Given this list of marker genes CEACAM18, TRIM15, NLRP6, SLC34A3, LINC01594, ACSL5, XDH, LINC00955, RNU6-36P, RPL13AP8, BTNL8, TMEM207, LCT (lactase), CEACAM19, PRKG2, TMIGD1, STRC, LINC01123, LHPP, ENPP7, PGPEP1, FGF23, ANXA13, GBA3, IGSF23, AGMAT, REEP6, TINAG (NCBI Gene Id 27283), NHERF4, TM6SF2 (transmembrane 6 superfamily member 2), MELTF, DEFA5, PDZD7, XPNPEP2, CLCA1, ERICH4, MUC12, WHAMM, C1QTNF12, DGAT1, CDX2, CUBN, CBLC, POFUT1, RNU6-439P, SLC26A3, SLC17A4, CA7, MALRD1, LBX2, ZBTB38, LPGAT1, KHK, PANCR, TPSG1, ACY3, FADS6 (NCBI Gene Id 283985), MYO1A, URAD, VIL1, SI, SPACA3, DNAJB7, BTNL3, GUCA2A, PVALEF, APOA4, SLC28A1, R3HDML, MIR4307HG, APRG1, FAM157A, RBBP8NL, CLCN1, RBP2, ENTPD7, PRSS48, CYP2W1, LCN15, MOGAT3, RPLP0P2, SLC13A2, MUC2, C3orf85, GPR35, MTTP, ANKRD40CL, SLC5A12, LINC02323, DEFA6, here is a description of the gene set: The gene expression program underlying the specification of human cell types is of fundamental interest. The study authors generated human cell atlases of gene expression and chromatin accessibility in fetal tissues. For gene expression, the study authors applied three-level combinatorial indexing to >110 samples representing 15 organs, ultimately profiling ~4 million single cells. The study authors leveraged the literature and other atlases to identify and annotate hundreds of cell types and subtypes, both within and across tissues. Our analyses focused on organ-specific specializations of broadly distributed cell types (such as blood, endothelial, and epithelial), sites of fetal erythropoiesis (which notably included the adrenal gland), and integration with mouse developmental atlases (such as conserved specification of blood cells). These data represent a rich resource for the exploration of in vivo human gene expression in diverse tissues and cell types. Human Gene Set: DESCARTES_MAIN_FETAL_INTESTINAL_EPITHELIAL_CELLS studied in species Homo sapiens from publication Cao J, O'Day DR, Pliner HA, Kingsley PD, Deng M, Daza RM, Zager MA, Aldinger KA, Blecher-Gonen R, Zhang F, Spielmann M, Palis J, Doherty D, Steemers FJ, Glass IA, Trapnell C, Shendure J (PMID 33184181) Marker genes curated from the annotated cluster as represented in the Descartes Human Gene Expression During Development database.